The following is a description of a gene set: Human Gene Set: GSE37301_HEMATOPOIETIC_STEM_CELL_VS_RAG2_KO_NK_CELL_DN Expression profiling of Rag2-deficient Ets1++ and Rag2-deficient Ets1-- mature NK cells and WT bone marrow progenitors, WT T cells, and WT Pro B cells Genes down-regulated in hematopoietic stem cells versus NK cells with RAG2 knockout. from publication Ramirez K, Chandler KJ, Spaulding C, Zandi S, Sigvardsson M, Graves BJ, Kee BL (PMID 22608498) species: Homo sapiens, and this is the list of marker genes: FAAH, PBXIP1, SDCBP2, IFNG, CEBPB, SERINC1, ATF4, MAF, RALGDS, ZBTB32, TNFSF11, GPRIN3, RNY3, ANP32E, MIR27A, PGRMC1, CHST11, WDR82, HSPA1A (NCBI Gene Id 3303), FOSB, RGS9, SCYL2, ULK2, TUBA1A, DNAJA4, FZD4, THAP11 (NCBI Gene Id 96844), CITED2, DDX6, CXCR3, CUL4A, DOCK2, NEK7, KLF6, PLK2, SGSM2 (NCBI Gene Id 9905), RHOB, HSP90AB1, TPPP, STAT4, GPR34, EBI3, MTMR3, PLCB4, EIF5A2, ETS1, ZFAND5, SINHCAF, AHNAK, CXCR5, HOPX, JMJD6, RNF128, IQGAP1, DCK, RORA, ARL4D, GATA3, ZFAND2A, PJA1, TNFAIP3, DPYSL2, SYT11, RILPL2, HGSNAT, PRKX, LENG9, LANCL3, TAGAP, HIP1R, ATP10A, JUNB, SNORD14E, TOX2, GPR183, PGAP1 (NCBI Gene Id 80055), POLG2, ATF3, ZEB2, OSTF1, IL18RAP, HSP90AA1, STMN1, CDR2, IL10, CHN1, DAP, EEA1, SNORD118, IL1RL1, NR4A1, WFIKKN2, SEC24A, NT5E, ADGRE5, RGS2, MBP, PRKAA1, HEXIM1, RGS1, CD28, RYK, SLBP, MT1A, CBFA2T2, ADORA2A, ITGA4, IKZF2, COBLL1, ARC, UBC, SLC35E4, HSPA2, ATP2B4, GPM6B, DUSP1, CEMIP2, GLA, PYGB (NCBI Gene Id 5834), ST6GALNAC3 (ST6 N-acetylgalactosaminide alpha-2,6-sialyltransferase 3), SLC4A7, TBC1D4, OLFML3, NCKAP1, IL10RA, CRIP1, CDK6, KCTD10, NEDD1, FDFT1, PTGER2, BTG2, SLC25A3, SIRT1, RAB5A, PLK3, ITGA7, PNP, ITGB1, PLP2, CWC25 (NCBI Gene Id 54883), DNAJB1, CDK1, MYO1F, SLC2A3, PROS1 (NCBI Gene Id 5627), ELF1, KLRK1, NABP1, GOT1, SEPHS2, MID1IP1, ENPP1, IL18R1, ATP9A, NRP1, FAM107B, PIM1, GLUD1, AGPAT2, AGPAT4, PTPRS (NCBI Gene Id 5802), CXCR6, CCR2, ENDOD1 (endonuclease domain containing 1), RAP1GAP2, EMP1, DUSP14, GADD45A, TAMALIN, CD69, HIPK1, SIK1, SPOCK2, ATCAY, SLC16A1, PHC3, PSENEN, ATP2B1, DMRTC2, STARD4, GGH, MBNL3